The following is a description of a gene set: from publication Sansom OJ, Reed KR, Hayes AJ, Ireland H, Brinkmann H, Newton IP, Batlle E, Simon-Assmann P, Clevers H, Nathke IS, Clarke AR, Winton DJ (PMID 15198980) Although Apc is well characterized as a tumor-suppressor gene in the intestine, the precise mechanism of this suppression remains to be defined. Using a novel inducible Ahcre transgenic line in conjunction with a loxP-flanked Apc allele we, show that loss of Apc acutely activates Wnt signaling through the nuclear accumulation of beta-catenin. Coincidentally, it perturbs differentiation, migration, proliferation, and apoptosis, such that Apc-deficient cells maintain a crypt progenitor-like phenotype. Critically, for the first time we confirm a series of Wnt target molecules in an in vivo setting and also identify a series of new candidate targets within the same setting. Top genes up-regulated at day 5 of Cre-Lox induced APC knockout in the intestine. studied in species Mus musculus Human Gene Set: SANSOM_APC_TARGETS_UP, and this is the list of marker genes: ZC3H8, CA12 (carbonic anhydrase 12), GGH, SLC1A4, WDFY1, BCAS2, GOLGA3, INTS7, IGFBP4, MCM2, HS3ST1, PRDX2, ETS2, TC2N, MRI1, KCNQ1, SLC39A14, EIF2S2, MSX1, TNNI1, POLI, DLK1, RECQL, AQP4, MYL7, MARCKSL1, HOPX, TCOF1, HUNK, DTYMK, TGFBR2, ACOT1, CD320, GNB1L, ZNF282, MSI1, TIAM1, TUBB2A, TRIB1, GLUL, MCM7, QSER1, MCM3, LRIG1, HES6, ADAT1, DYRK3, CTPS1 (CTP synthase 1), ZNF746, MYCL, CDC37, SHF, ATL3, CYBRD1, KRT18, SLC40A1, TXNRD3, AGR3, TMEM131L, MCM6, EPHB3, EPHB2, ACER2, EHF, SP5, POLR1HASP, NR2E3, CHRNB4, EPOP, RPL14, ANG, GTF3C4, SOX17, KRT23, PAXIP1, IMPA2, CPN1, PSAT1, TCF7, FOXA3, URI1, SOX4, TGIF1, CDCA7, ECT2, HNRNPA1L2, CD44, ERGIC1, UNG (NCBI Gene Id 7374, uracil DNA glycosylase), ASCL2, UBE2T (NCBI Gene Id 29089), AXIN2, DTL, VN1R17P (vomeronasal 1 receptor 17 pseudogene), RGCC, NECTIN4, ZNF318, SNHG6, MEG3, SOX9, PIWIL2, IMPDH2, SKP2, TLR7, PAICS, PARP1, RPP14, RNF43, REC8, TUBB2B, OXCT2, TNFRSF12A, EMP2 (epithelial membrane protein 2), TRPC2, NPC1, RNASE4, CITED1, CCND2, PSMG2, DIAPH3, PASK, SLC12A2, CCDC86, MAD1L1, SNAPC2, EGR1, ABCC5, KAT2A, SGF29, MT4, TNFRSF19 (TNF receptor superfamily member 19)